The following is a description of a gene set: from publication Kress E, Hedges JF, Jutila MA (PMID 16423401) Genes up-regulated in Vd1 gamma delta T cells: LPS versus phorbol myristate acetate and ionomycin. species: Homo sapiens The two major human gd T cell subsets, Vd1 and Vd2, display differences in tissue tropism and agonist responses, but we have little insight into global differences that may exist at the gene expression level. This is due to the small numbers of these cells that can be obtained from healthy donors, which limit comprehensive, comparative gene expression analyses. We established a culture method that expands Vd1 and Vd2 cells from the same PBL preparation to levels sufficient for sorting and microarray analysis. Although the subsets were expanded identically (anti-TCR mAb, plus IL-15), 392 and genes were identified, which were differentially expressed in the two subsets, from two donors, respectively. Approximately genes changed in both subsets following PMA/ionomycin treatment; about 50% of these genes were subset-specific. Both subsets responded to a crude LPS preparation, but only 6% of the responsive genes were the same. The differentially expressed genes were consistent with Vd2 cells being more inflammatory and Vd1 cells having more of a regulatory phenotype. Both subsets expressed transcripts encoding an array of innate and NK cell receptors, supporting the relationship of gd T cells to the innate immune system. Our results show that circulating Vd1 and Vd2 subsets in humans have considerable, inherent differences in gene expression following treatment with non-TCR agonists, supporting unique functional roles for these cells in vivo. Human Gene Set: GSE3720_LPS_VS_PMA_STIM_VD1_GAMMADELTA_TCELL_UP, and this is the list of marker genes: ACTR1B, FAM171B, FBXL12, FBLN1, MINDY3, CCPG1, AGPAT2, XAF1, CMAS, KLRC2, PPP3CC, IFNAR2, AZI2, PPCDC, IL18RAP, GSDMD, GABARAPL1 (GABA type A receptor associated protein like 1), RALB, NR2C2, B2M, NGB, RNF38, ARIH2, CCDC62, CD226, KCNJ8, H3-3B, CREBL2, FASTKD3, IMP4, MIB2, ZMYM5, GSPT2, GZMB, NELFCD (negative elongation factor complex member C/D), MORN3, KRT16, PYCARD, NCKAP1, EMP1, GBP4, BIN2, CD47 (NCBI Gene Id 961), FGL2, PRAM1, CDC42, ETFB (NCBI Gene Id 2109), SMN1, RAI2, CD3G, GZMK, PMAIP1, RNFT1 (ring finger protein, transmembrane 1), KLRC1, MPC2, PLCXD3, NUDT10, RPAP2, KLRD1, PCP4L1, PKP4, TOMM20, ARF6, NAXE, MAD2L1, LGALS3, MDM1, MT-CO1, CERS2, LIN9 (lin-9 DREAM MuvB core complex component), SLC50A1, RNF24, CYFIP1, HCN1, RUFY3, TECRL, ZEB2, MIR191, TMEM71, TSEN34, GZMA, ACYP2, SLC33A1, MICAL1, RPL39, RAG2, BRI3BP, IL16, SERPINB9, CARNS1, ANKRA2, TST, GNAI2, SLAMF7, MGAT2, CRLS1, ARHGEF12, UBXN11, ARAF, CBX7, LYZL6, MT-CYB, ENTHD1, STARD10, RDM1, C1S, MC4R (melanocortin 4 receptor), STMN4, NIPAL4, NIPBL, CENPQ, CAPN11, SLAMF1, KLHL2, MRPL18, PPP2R3A, CYRIA, CEP170, GPC2, CD52, GDF9, TPCN2, CDHR1, PDCL2, SNAPC3, RNF138, PANX3, SRF, MROH2A, SIKE1, ANXA1, S100A4, SPOPL, DTX3, FFAR2, MBD3L2, KDM4D (NCBI Gene Id 55693), CYB561D2 (cytochrome b561 family member D2), RPL9, S1PR5, MS4A4A, ACAT1